Given this list of marker genes Tap2, Daxx, Jaml, Ogfr, Cers6, Bbx, Tgtp1, Ms4a4c, Snx2, Znfx1, Acadl, Grina, B4galt5, Ly86, Cnp, Psmb9, Casp4, Prpf38b, Ifi27, Tmcc3, Gbp8, Helz2, Fbxw17, Serpina3g, Psmb8, Ctsc, Phf11b, Apod, Dhx58, Cd86, Ifitm3, Psmb10, Plaat3, Aida, Tmem184b, Usp25, Tor1aip2, Actr2, Ccdc6, Cflar, Anapc5, Ifi206, Dek, Trim30d, Xaf1, Tor1aip1, Tcf4, Irf9, AI837181, Ifi214 (NCBI Gene Id 545384), Ifit3, Tent5a, Sp100 (NCBI Gene Id 20684), Zup1, Phf11a, Parp14, Ube2l6, Parp12, Ifi209, Nampt, Pml, Dnajc7, Xrn1, Cdkn1a, Ifih1, Phf11c, Cd274, Mthfd2, Trafd1, Trim12a, Ifit2, Oasl1, Pnp, Slfn9, Cptp, Asb13, Capza2, Oas1a, Fgl2, Ifi203, 9930111J21Rik2, Nup88, Rnf213, Calhm6, Ifit1 (interferon-induced protein with tetratricopeptide repeats 1), Samhd1, Ifi47, Sass6, Ifi27l2a, Tspo, Tdrd7, Lgals3bp, Mxd1, Myd88, Cxcl10, Macroh2a1, Stard3, Mbd2, Irf7, Marchf5 (membrane associated ring-CH-type finger 5), Cxcl9, Dbnl, Parp11, Stxbp3, Trim25, Adar, Ccrl2, Anxa4 (annexin A4), Fam241a, Trim12c, Atp8a1, Il21r, Anxa1, Slc2a6, Dennd1b, Prkx, Il15ra, Oasl2, Eif2ak2, Zfp800, Larp1, Cited2, Cd47, Cd52, Lima1, Krit1, Ctss, Max, Sp140 (Sp140 nuclear body protein), Cmtm6 (NCBI Gene Id 67213), Tcof1, Dpy19l1, Ly6a, Mndal, Zc3h7a, Ccnd2, Psip1 (PC4 and SFRS1 interacting protein 1), Usp15, Sppl2a, Iigp1, Ifi204, Aff1, Pkib, Slfn5, Tomm70a, Irgm1, Sdc3, Nr4a3, Arf4, Mitd1, Cln3, H2-T22, Bst2, Atp1b3, Tlk2, Trim34a, Ccdc86, Gbp7, Cyp27a1, Gng12, Itm2b, Gramd2b, Tmbim6, Otud5, Stat1, Tapbp, H2-T23, Snx4, Il15, Tmem140, Phip, Nt5c3, Tor3a, Ifit3b, Herc6, Usp18, Parp9, Anxa7, Mov10, Serinc3, Ifi207, Dtx3l, Pttg1 (pituitary tumor-transforming gene 1), Usp12, Lgals9, Isg20, Rtp4, Irf2, Slfn8, Grn, Ifi35, Flnb, Gbp4, Tmem219, Synj1, Ddx60, Il10ra, Isg15, Ankib1, Shisa5, Ehd4 (NCBI Gene Id 99247), Inpp5b, Atp6v1d, Ifit1bl1, Clic4, Rnf114, Keap1, Morc3, Gbp3, Selenow, Ifi211, Ccr7, Oas3, Rbl1, Glipr2, Dcp2, Ly6e, Rasa4, Bcl2l11, Mx1, Svbp, Tap1, Nmi, Ascc3 (activating signal cointegrator 1 complex subunit 3), Zbp1, Mob1a, Nfe2l1, Fbrsl1, Sat1, Gbp5, Marcksl1, Rsad2, N4bp1, Slc25a22, Stat2, Rap1b, Nsd3, Cttnbp2nl, Ppm1k, Csrp1, Rab8b, Map2k1 (NCBI Gene Id 26395), Ms4a6c, Samd9l, Mycbp2, Plac8, Phf11d, Selenot, Dnase1l3, Uba7 (NCBI Gene Id 74153), Ifi208, Cmpk2, Anxa5, Phc2, Gbp2, Gbp9, Dse, Pmepa1 (NCBI Gene Id 99365), Parp10, Clec2d, Chmp4b, Setdb2, Ppa1, Txn1, Fndc3a, Igtp, Arhgap8, Klrk1, Zc3hav1, Ifi205, Trim30a, Mthfr, Prkcd (NCBI Gene Id 52581), Irgm2, Plin2, Baz1a, Ifi213, Etnk1, Rigi, Sap30, Sp110, Dnaja2, Slfn2, Slfn1, here is a description of the gene set: from publication Cui A, Huang T, Li S, Ma A, Pérez JL, Sander C, Keskin DB, Wu CJ, Fraenkel E, Hacohen N (PMID 38057668) Cytokines mediate cell-cell communication in the immune system and represent important therapeutic targets. A myriad of studies have highlighted their central role in immune function, yet we lack a global view of the cellular responses of each immune cell type to each cytokine. To address this gap, the authors created the Immune Dictionary, a compendium of single-cell transcriptomic profiles of more than 17 immune cell types in response to each of 86 cytokines (>1,400 cytokine-cell type combinations) in mouse lymph nodes in vivo. A cytokine-centric view of the dictionary revealed that most cytokines induce highly cell-type-specific responses. For example, the inflammatory cytokine interleukin-1β induces distinct gene programmes in almost every cell type. A cell-type-centric view of the dictionary identified more than 66 cytokine-driven cellular polarization states across immune cell types, including previously uncharacterized states such as an interleukin-18-induced polyfunctional natural killer cell state. Genes positively differentially expressed in cell type: MigDC (migratory dendritic cell) upon treatment with cytokine: IFN-β in mouse lymph nodes in vivo. studied in species Mus musculus Mouse Gene Set: CUI_MIGDC_IFNB_RESPONSE_UP